Given this list of marker genes PPP1R14A, PRXL2A, ZEB2, MGLL, UTRN, DLC1, TLE5, SELENBP1, FILIP1L, ADAMTS12, TGFB3, SGCE, CCNL2, PLXDC1, SELENOW, EHD2, TLE1, CLMN, ELOVL5, ZHX1, STK38L (serine/threonine kinase 38 like), SPTBN1, TACC1, GLRX5, FBLIM1, GUCY1B1, HIC1, ARHGEF17, PLN, DYNC1I2, ADGRA2, BACH1, CD248, MYLK, UACA, ODF2L, HSD17B11, ENPEP, B3GNT2, DICER1, KNOP1, ITGA1, HSD11B2, WDFY2, TGFB1I1 (transforming growth factor beta 1 induced transcript 1), SLC25A5, FAM162B, TBC1D1, TBX2-AS1, ITGA7, CCDC102B, CARD16, ARHGEF2, ADAR, MYO1B, PDE8A, A2M, COL5A3, ARHGAP42, LHFPL6, VASP, ASAP2, GUCY1A1 (NCBI Gene Id 2982), RNF152, EBF1, RERG, SH3RF1, MAP3K20, ETS1, PLSCR4, OAZ2, RGS5, EIF3K, JAG1, SGIP1, SEMA5A, TMOD3, SH3BGRL, LDHB, ADISSP, PTK2, ISYNA1, TNS1, GJC1 (NCBI Gene Id 10052), RASL12, KCNJ8, PRKG1, BAZ2A, MPRIP, DYNC1H1, PPP1R12A, GPM6B, ADAMTS1, HIGD1B, EDNRA, PELO, ABCC9, NR2F2, HSPA5, GBP2, EPB41L1, TBX2, JAK1, COX4I2, FHL3, PHC2, C5orf24, GJA4, EPS8, HLA-F, ANO1, MMP9, HGF, ARPC5, CAV2, KMT2E, CAMK2N1, COX7B, NRP1, DCBLD2, JAM3, EPHX1, LPL, CARMN, SLC25A6, REV3L, here is a description of the gene set: Human Gene Set: SU_HO_CONV_CENT_CHONDROSARCOMA_STROMAL_C5_VASCULAR_SMOOTH_MUSCLE_CELL from publication Su Z, Ho JWK, Yau RCH, Lam YL, Shek TWH, Yeung MCF, Chen H, Oreffo ROC, Cheah KSE, Cheung KSC (PMID 38267611) The transformation of benign lesions to malignant tumours is a crucial aspect of understanding chondrosarcomas, which are malignant cartilage tumours that could develop from benign chondroid lesions. However, the process of malignant transformation for chondroid lesions remains poorly understood, and no reliable markers are available to aid clinical decision-making. To address this issue, we conducted a study analysing 11 primary cartilage tumours and controls using single-cell RNA sequencing. By creating a single-cell atlas, we were able to identify the role of endoplasmic reticulum (ER) stress in the malignant transformation of conventional central chondrosarcomas (CCCS). Our research revealed that lower levels of ER stress promote chondrosarcoma growth in a patient-derived xenograft mouse model, while intensive ER stress reduces primary chondrosarcoma cell viability. Furthermore, we discovered that the NF-?B pathway alleviates ER stress-induced apoptosis during chondrosarcoma progression. Our single-cell signatures and large public data support the use of key ER stress regulators, such as DNA Damage Inducible Transcript 3 (DDIT3; also known as CHOP), as malignant markers for overall patient survival. Ultimately, our study highlights the significant role that ER stress plays in the malignant transformation of cartilaginous tumours and provides a valuable resource for future diagnostic markers and therapeutic strategies. A blood vessel cell population detected with low abundance (0.59% of total cells). It expressed THY1, COLIAI/Collagen I, ACTA2, and RGS5. species: Homo sapiens